The following is a description of a gene set: species: Homo sapiens Interrupted inferior vena cava with azygous continuation Interrupted inferior vena cava with azygous continuation is the result of connection failure between the right subcardinal vein and the right vitelline vein. Consequently, venous blood from the caudal part of the body reaches the heart via the azygous vein and superior vena cava. Human Gene Set: HP_INTERRUPTED_INFERIOR_VENA_CAVA_WITH_AZYGOUS_CONTINUATION, and this is the list of marker genes: ACVR2B, SMOC1, KDM3B, MMP21, DNAH9